Given this list of marker genes Uba52, Tsc22d3, Btg2, Fos, Btg1, Zfp36l2, Hspa1a, Hspa1b, Jun, Crip1, Klf6, Pdcd4, here is a description of the gene set: species: Mus musculus Genes negatively differentially expressed in cell type: CD8+ T cell upon treatment with cytokine: IL-21 in mouse lymph nodes in vivo. from publication Cui A, Huang T, Li S, Ma A, Pérez JL, Sander C, Keskin DB, Wu CJ, Fraenkel E, Hacohen N (PMID 38057668) Cytokines mediate cell-cell communication in the immune system and represent important therapeutic targets. A myriad of studies have highlighted their central role in immune function, yet we lack a global view of the cellular responses of each immune cell type to each cytokine. To address this gap, the authors created the Immune Dictionary, a compendium of single-cell transcriptomic profiles of more than 17 immune cell types in response to each of 86 cytokines (>1,400 cytokine-cell type combinations) in mouse lymph nodes in vivo. A cytokine-centric view of the dictionary revealed that most cytokines induce highly cell-type-specific responses. For example, the inflammatory cytokine interleukin-1β induces distinct gene programmes in almost every cell type. A cell-type-centric view of the dictionary identified more than 66 cytokine-driven cellular polarization states across immune cell types, including previously uncharacterized states such as an interleukin-18-induced polyfunctional natural killer cell state. Mouse Gene Set: CUI_T_CELL_CD8_IL21_RESPONSE_DN